The following is a description of a gene set: Any process that modulates the frequency, rate, or extent of homotypic cell-cell adhesion. Human Gene Set: GOBP_REGULATION_OF_HOMOTYPIC_CELL_CELL_ADHESION studied in species Homo sapiens, and this is the list of marker genes: MAP2K1, PRKCQ, PRKG1, ADGRG1, PRKCD (protein kinase C delta), IL6, CCL5, PLPP3, C1QTNF1, MFSD2B, F11R, CD9, PDPN, CTSG, LYN, JAK2, PLAUR, SH2B3, CTNNB1, ANK3, CELA2A (chymotrypsin like elastase 2A), UBASH3B, EMILIN1, TNFSF11, SERPINE2, IL6ST, EMILIN2, CEACAM1, ALOX12, IL6R, SYK, RDX, ADAMTS18, TMX1, PRKCA, GP6, VPS33B, JAK1, ZNF703, HTR2A, MMRN1